The following is a description of a gene set: species: Homo sapiens Binding to an adrenergic receptor. Human Gene Set: GOMF_ADRENERGIC_RECEPTOR_BINDING, and this is the list of marker genes: APLP1, ADRB1, GRIA1, UCHL1, NEDD4 (NCBI Gene Id 4734), DLG4, RAPGEF2, NHERF1, ADRA2A, ADRB3, ADRA2C, GRK2, AKAP5, MAGI2, GNAS, C1QBP, PDE4D, ARRDC3